The following is a description of a gene set: from publication Elo LL, Järvenpää H, Tuomela S, Raghav S, Ahlfors H, Laurila K, Gupta B, Lund RJ, Tahvanainen J, Hawkins RD, Oresic M, Lähdesmäki H, Rasool O, Rao KV, Aittokallio T, Lahesmaa R (PMID 20620947) species: Homo sapiens Human Gene Set: GSE17974_0H_VS_1H_IN_VITRO_ACT_CD4_TCELL_UP The aim of this dataset was to study in detail the transcription kinetics initiated by cytokine IL-4 in early differentiation of Th2 cells. Genes up-regulated in comparison of untreated CD4 T cells at 0 h versus the untreated cells at 1 h., and this is the list of marker genes: NFIC, PIM1, TEKT2, ZNF625 (zinc finger protein 625), CABP2, CXXC5, ARSL, EBPL, USP48, HLA-DOB, ZNF75D, BIN1, GSS, GAA, ERBB2, ENSG00000280119, JRK, PRPSAP2, RASSF7, CCZ1B, PSMD4, ST3GAL2, ARHGAP10, GDPD3, NFKBIZ, TMEM106B, SQOR, TPM2, ITGAM, NSUN5P1, HDHD5, SPPL2C, SGCE, COQ4, RPAP1, DUSP1, JAML (junction adhesion molecule like), TMIGD2, ARSA, BTG4, TPST1, DCTN2, LAMTOR4, HCK, PPP1CA, DYNLRB1, TRIB3, ASB16-AS1, C6orf226, VPS26B, ZNF319, CCDC71L, PTGR3, IRAK4, MYG1, NIT2, TBC1D10A, CEP89, DCP2, ZMYM3, APEH, VPS9D1, ING4, GAL3ST4, CCDC124, SLC9A3-OT1, TMEM179B, ALKBH7, APRG1, NAPB, LMF2, SP140, ZMYND8, ID2, TRABD2A, RGS2, NPEPPSP1, CEP78, ITGB7, TSC22D1, SMCR5, RNF207, SHMT2, NUP210, VMO1, KLF4, PIGC, H2BC15, JUN, PLOD1, NVL (NCBI Gene Id 4931), ACAP1, SGSM3, ZNF792, OCRL, CES4A (NCBI Gene Id 283848), SH3BP2, PCIF1, RPS6KA1, ADGB, SH2D4A, VILL (villin like), TP53AIP1, CLEC4E, TBC1D22A-AS1, CDCA7 (cell division cycle associated 7), GALNT7, LBH, GPR143, IFFO1, IL11RA, IRGM, CCDC13-AS1, MEIG1, COMMD8, PPP3CC, CAPRIN2, GADD45A, TARBP1, LINC00173, TRANK1, GSDMB, C16orf74, DMRTA1, DIS3L2, CASP1, SOX14 (SRY-box transcription factor 14), SHOX, SOCS3, CMTM7, LDAH, PDLIM2, CIAO2A, ADARB1, KXD1, H2BC21, ENSG00000240207, PIH1D1, TSC22D4, ATOH7 (NCBI Gene Id 54719), CFL2, PRR7-AS1, FAM24B, HDDC3, TAMM41, GGCT, IFI30, CLEC11A, NME4, RP9P, RTP5, TAAR1, MRI1, XXYLT1, THAP4, LINC00955, HEMK1, SSBP4 (single stranded DNA binding protein 4), PFKL, NME3, THBS3, STOML1, TMEM42, TGFB3, NMRK1, GABBR1, ZNF844, NAA40, COMMD7, STX10 (syntaxin 10), PET117 (PET117 cytochrome c oxidase chaperone), A1BG-AS1, TAFAZZIN, ARRDC3, SOCS1 (NCBI Gene Id 8651), FSTL4, LILRB1, SLC9A3-AS1, ATG16L2, FAM226B, ABHD3, LIME1, OXER1, SLC25A22, PGP, SMARCD3, VIPR1, FAM78A, PATL2, PDE4DIP, G0S2, TRADD, DACT1